Given this list of marker genes Emc9, Emc3, Emc6, Emc1, Emc4, Mmgt1, Emc7, Emc10, Emc2, Emc8, Mmgt2, here is a description of the gene set: studied in species Mus musculus A transmembrane protein complex located in the endoplasmic reticulum (ER) involved in the insertion of newly synthesized proteins in the membrane of the ER. In S. cerevisiae, it has six members: EMC1, EMC2, AIM27, EMC4, KRE27, and EMC6. Mouse Gene Set: GOCC_EMC_COMPLEX